Given this list of marker genes LMNA (NCBI Gene Id 7816), BCR, DVL1, C2CD3, GLI1, NXN, TBX22, NEK1, TCTN3, GRHL3, CPLANE1, POU4F1, SETBP1, IRF6, MMP1, TBC1D24, EFTUD2, OFD1, MID1, ADNP, SETD5, TOPORS, RSPO2, TBR1, MAPK1, NR4A2, FAM149B1, IFT57, ATP6V1B2, PDE6D, WDR35, CHUK, IFT140 (NCBI Gene Id 9742), TAF4, RIPK4, SCNM1, DYM, WNT5A, CDK13, PRKACB, DYNC2LI1, KIAA0753, CDC42BPB, H4C5, FBXO11, ZMPSTE24, CD96, FAM111A, FREM1, KIF7, GLI3, PRR12, KIAA0586, CRKL, PRKACA, B3GLCT, AFF3, SPTBN1, TMEM231, ROR2, KMT2D, COL7A1, EVC2, DDX59, COL3A1, SMARCA2, EVC, FLNA, TELO2, SLC37A4, TMEM216, here is a description of the gene set: An abnormality of the lingual frenulum, that is of the small fold of mucous membrane that attaches the tongue to the floor of the mouth, or the presence of accessory frenula in the oral cavity. Abnormal oral frenulum morphology Human Gene Set: HP_ABNORMAL_ORAL_FRENULUM_MORPHOLOGY species: Homo sapiens